The following is a description of a gene set: species: Homo sapiens Human Gene Set: HP_ABNORMALITY_OF_THE_TONGUE_MUSCLE Abnormality of the tongue muscle, and this is the list of marker genes: LARGE1, GMPPB, FKRP, POMT1, POMT2